Given this list of marker genes NARS2, XPC, ATP11A, MAG, RNF220, MPZ, AHCY, KCNJ10, PEX12, RNF113A, SLC12A6, REPS1, HMBS, PDX1, PTRH2, SLC30A10, LRPPRC, AGTPBP1, INS, DCAF8, COX20, ZFHX3, BMP6, GBA2, ALDH4A1, ATP7B, AARS1, DARS2, PIEZO2, SCO2, RETREG1, OPA1, FBN1, NF2, RTN2, NRCAM, GTF2H5, HNRNPA2B1, SLC25A46, COASY, TBCD, DMD, MYO9A, AIFM1, NOTCH3, ERBB2, MYOT, INSR, TPI1, TUBB3, SCN9A, TRPV4, POLG, PLAAT3, PRICKLE1, ATP5F1A, KLHL9, STAT3, INF2, TTR, RAB3GAP2, SCYL1, DNAJC3, SAA1, GAN, HLA-DPA1, MME, DMXL2, APTX, HSPB1, MT-TF, TIMMDC1, POLR3A, IDUA, AFG3L2, GALC, PEX5, KRAS, RAB3GAP1, NAGLU, PNKP, LAMA2, ACER3 (alkaline ceramidase 3), GMPPA, ABCA1, PLEKHG4, ATP1A1, SUCLA2, NGLY1, ELP1, MOGS, AP5Z1, ERCC6, SNAP29, RPIA (NCBI Gene Id 22934), HYCC1, GLE1, PSMC3, ERCC5, TTBK2, HSD17B4, CLP1, PNPLA6, RNF168, MTRR, PLP1, SCP2, DDB2, PEX7, SLC5A7, RNF170, HARS1, SGPL1, NFU1 (NCBI Gene Id 80767), TARS1 (NCBI Gene Id 94887), RNASEH1, PMM2, KLC2, ABHD12, PTRHD1, ELOVL4, PI4K2A, CYP2U1, SCN11A, TFG, LITAF, CYP7B1, ALAD, MT-ND4, SAMHD1, HADHB, HSPB3, ERCC1, NOTCH2, FXN, GCLC, GJB6, TRMT5, MT-TH, TRIM2, SETX, SLC25A4, VRK1, PEX1, LDB3, ATXN10, PHYH, MPV17, RNU7-1, DDHD1, TRIP4, SCARB2, MT-CO3, CD59, WDR48, SMC1A, DHX9, KIF1B, DST, MFN2, HK1, NEUROG1, RNU4-2, MRE11, CTSD, COA3, WAS, IFRD1, SACS, WNK1, P4HA2 (prolyl 4-hydroxylase subunit alpha 2), GBA1, RAB7A, RFC1, ELOVL5, COX6A1, ARL6IP1, KIF1A, PEX10, SPTLC1, NAGS, IGHMBP2, RNASEH2A, DKK1, AP1B1, PNPT1, FDX2, FLRT1, EXOSC8, RMND1, TIMM8A, PLXNA1, MARS1 (methionyl-tRNA synthetase 1), CPOX, MT-ND3, ABCD1, SLC25A19, MCM3AP (minichromosome maintenance complex component 3 associated protein), SYNE1, LYST, ALS2, GSN, MT-ND4L, CLCN6, IFIH1, SAMD9L, POLR3B, CHAT, PLA2G6 (phospholipase A2 group VI), MYH14, ADAT3, HLA-DQA1, NDUFS2, RYR1, NDRG1, ERCC8, HADHA, BIN1, ERCC3, HNRNPA1, GCK, HLA-DQB1, PRKAR1A, ZFYVE26, COA8, LIG3, GNAS, ITPR3 (inositol 1,4,5-trisphosphate receptor type 3), ERLIN2, HLA-DRB1, PPP2R2B, ATP5F1E, SPTAN1, DNM1L (dynamin 1 like), MT-ATP8, CTLA4, MYD88, IARS2, TTPA, DEAF1 (DEAF1 transcription factor), CPSF3, AIP, UBA1, GTF2E2, NF1, XK, DNAJC30, HINT1, NEFL, TMEM70, MT-TK, CCND1, PDK3 (pyruvate dehydrogenase kinase 3), BTNL2, CARS1, COQ4, ITPR1, PRF1, WARS1, FAH, FMR1, TEFM, RRM1, UQCRC1, ERBB3, ATXN1, MT-CYB, CD28, MT-CO1, ACOX1, PTPN22, PMPCA, SNAP25, MT-TV, VPS13D, IDS, VPS13A, NEMF, TGFB1, PRPS1, DYNC1H1, RAD21, AGXT, WFS1, MT-CO2, GARS1, TNXB, HFE, ATP5MK, HSPB8, SMPD1, DHH, SPG21, HEXB, ACO2, MORC2, KIF5A, POLG2, MT-TS2, HLA-DPB1, SHMT2, AGRN, REEP1, DNMT1, KIF1C, ATXN8OS, HDAC8 (histone deacetylase 8), KRT14, DHX16, DPM1, GCDH, SERPING1, UNC13D, BRAF, COA7, FGF14, GDAP1, ATAD3A, HADH, KCNK9, TGM6, ATL1, CISD2, PEX11B, IBA57 (NCBI Gene Id 200205), TRAPPC11, STXBP2, B2M, VCP, MT-ND5, AMACR, RNASEH2C, KPNA3, EXOSC9, ALDH18A1, RNASEH2B, SLC5A6 (NCBI Gene Id 8884), MT-ATP6, NGF, TWNK, ATXN3, EXOSC3, SIL1, OSTM1, ERCC2, NIPBL, PLOD1, PDSS1, SCN10A, SPG11, SPTBN4 (spectrin beta, non-erythrocytic 4), KCNJ11, PIGB, ARSI, SYT2, LETM1, FGA, PHF6 (NCBI Gene Id 84438), PEX6, SPG7, BSCL2, AMPD2, SLC25A1, PDE4D, CACNA1A, MT-TL1, PLD3, WIPF1, KRT5, ATPAF2, KARS1, GRM1, SPTBN1, MFF, ATP5F1D (ATP synthase F1 subunit delta), SLC52A2, FLNC, LYZ, MT-ND6, SEPTIN9, PRTN3, CYP27A1 (cytochrome P450 family 27 subfamily A member 1), COL13A1, UCHL1, C19orf12, DSTYK, ENSG00000288330, TK2, PPOX, MICU1, GBE1, TYMP, SLC18A3, MANBA, COQ7, TREX1, DNM2, MT-ND2, DEGS1 (NCBI Gene Id 8560), CAPN1, ARSA, GJB2, ATP13A2, VAMP1, MGAT2, TBCE, SLC46A1, MYF6, MPLKIP, CLCF1, PDYN, RAI1, PSAP, CADM3, EDNRB, FUCA1, GNB2, DNASE1L3, COMP, SOX10, XRCC1, GPR101, SMC3, ADA2, CTDP1, B4GALNT1, TNFRSF1B, IRF4, HLA-B, SH3TC2, EGR2, NARS1, LSM11, SELENOI, NEFH, MPC1, RRM2B, TAF6, MTMR14, PIK3R5 (phosphoinositide-3-kinase regulatory subunit 5), MT-TE, MTHFR, ARSB, MTRFR, ABCC8, FBLN5, GJB1, AP1S1, AAAS, CRAT, TBC1D20, TBC1D24, ADAR, FLII, HSD3B7, ERCC4, ATP6V1B2, MT-ND1, LMNA, ZFR, BRD4, VPS41, CA2, PMP22, PEX16, RAB18, IQSEC2, SPTLC2, XPA, GJC2, COG8 (NCBI Gene Id 84342), SURF1, FA2H (NCBI Gene Id 79152), CAPRIN1, STX11, XRCC4, ATL3, VWA1, TXN2, ASCC1, DGUOK, ATP1A3, SLC52A3, BCKDK, MT-TW, MT-TQ, NAGA, CCT5, GNPTAB, EMILIN1, BAG3, TDP1, GET4, AR, TOP3A, here is a description of the gene set: Peripheral neuropathy studied in species Homo sapiens Peripheral neuropathy is a general term for any disorder of the peripheral nervous system. The main clinical features used to classify peripheral neuropathy are distribution, type (mainly demyelinating versus mainly axonal), duration, and course. Human Gene Set: HP_PERIPHERAL_NEUROPATHY